The following is a description of a gene set: The series of events required for an organism to receive a gustatory stimulus, convert it to a molecular signal, and recognize and characterize the signal. Gustation involves the direct detection of chemical composition, usually through contact with chemoreceptor cells. This is a neurological process. Mouse Gene Set: GOBP_SENSORY_PERCEPTION_OF_TASTE studied in species Mus musculus, and this is the list of marker genes: Tas2r135, Rtp3, Trpv1, Tas2r126, Lef1, Scnn1b, Tas2r102, Wnt10b, Ffar4, Calhm1, Reep2, Tas2r129, Tas2r122, Pkd1l3, Tas2r114, Tas1r2, Tas2r130, Tas2r108, Tas2r117, Gnat1, Tas2r113, Gnat2 (G protein subunit alpha transducin 2), Calhm3, Plcb2, Rgs21, Car6, Tas2r121, Tas2r107, Tas2r106, Asic1, Rtp4, Lpo, Tas2r105, Tas2r139, Tas1r1, Tas2r136, Tas2r124, Rtp2, Cd36, Pigr, Scnn1g, Pkd2l1, Itpr3, Tas2r143 (NCBI Gene Id 387514), Asic3, Gnb1, Tas2r125, Asic2, Tas1r3, Scnn1a, Tas2r134, Pip, Tas2r144, Tas2r140, Tas2r109, P2rx2, Tas2r110 (taste receptor, type 2, member 110), Gng13, Tmc4, Tas2r131, Tas2r115, Tas2r104, Tas2r116, Tas2r120, Tas2r103 (taste receptor, type 2, member 103), Tas2r119, Rtp1, Gnat3, Tas2r138, Tas2r123, Azgp1, P2rx3, Tas2r137, Tas2r118 (NCBI Gene Id 387347)